The following is a description of a gene set: species: Mus musculus Mouse Gene Set: GOBP_POSITIVE_REGULATION_OF_CELL_ADHESION_MEDIATED_BY_INTEGRIN Any process that activates or increases the frequency, rate, or extent of cell adhesion mediated by integrin., and this is the list of marker genes: Ptpn6, Ccl21a, Ccl21f, Ccl5, Ccl21d, Foxc2 (forkhead box C2), Cxcl13, Tgfb2, Itgb3, Cib1, Cd3e, Ccl21e (NCBI Gene Id 100504239), Cd24a, Ret, Ccl21b, Fermt1, Lif, Podxl, Ift74, Nckap1l, Rac3, Piezo1, P2ry12, Skap1, Syk, Adam9